The following is a description of a gene set: studied in species Mus musculus Any process that modulates the frequency, rate, or extent of a process that reduces the internal pH of a cell. Mouse Gene Set: GOBP_REGULATION_OF_CELLULAR_PH_REDUCTION, and this is the list of marker genes: Bcl2, Car7, Avp, Car2, Slc9a7, Avpr1a (arginine vasopressin receptor 1A), Ube3a, Slc9a8